The following is a description of a gene set: Human Gene Set: GSE24972_WT_VS_IRF8_KO_MARGINAL_ZONE_SPLEEN_BCELL_UP Conditional IRF8 KO mice (mice with a conditional allele of Irf8 crossed with CD19-Cre mice) showed increased numbers of both Gene expression data spleen marginal zone (MZ) and Gene expression data spleen follicular (FO) B cells compared to control mice. To evaluate gene expression patterns that distinguished FO or MZ B cells derived from conditional KO and control mice, we used Affymetrix GeneChip® Mouse gene 1.0 ST Array. from publication Feng J, Wang H, Shin DM, Masiuk M, Qi CF, Morse HC 3rd (PMID 21178004) species: Homo sapiens Genes up-regulated in spleen marginal zone B lymphocytes: wildtype versus IRF8 knockout., and this is the list of marker genes: HEMGN, SLC2A8, EXTL3, GATA6, GATA1, ADAMTS1, RAB39A (NCBI Gene Id 54734), HSPB1, SFMBT2, MDP1, ADAM8 (ADAM metallopeptidase domain 8), CARHSP1, ARHGEF12, TRPC4, MT1E, CAPN2, PCMTD2, NRG4, RBM47, ELOF1, CSRNP1, CTDSP1, NR2C2AP, SLC22A16, TMEM222 (transmembrane protein 222), CCDC59, ZNF740, CFAP119, IL1RN, IRF2BPL, ACTR10, WIPI2, KANSL1 (NCBI Gene Id 791085), PORCN, MCEE, SLMAP, MST1R, MRPL2, FMO5, AFAP1L1, UFM1, INPP4A, WDR45, STX5, GUSB, LMNA, PAPOLB, COX4I1, TMEM150B, CYP2R1, PDZD11, TMTC3, WIPI1, CEPT1, SH3PXD2B, FABP4, FASTKD1, MYD88, NAB1, COL18A1 (collagen type XVIII alpha 1 chain), KLF15, BABAM1, RCSD1, RTCB, ZC3H15, DDHD1, GDA, ARHGAP19, PIGA (NCBI Gene Id 5277), PMP2, RNF169, ABL2, MED27, MGST3, INAFM1, SMURF2, SUCLG2, GAS6, RPL22L1, RGS1, KCNK6, RNASEL, FRAT1, MTDH, TMEM87B, NAAA, SNX14, ID1, RBSN, MTSS1, DRC1 (NCBI Gene Id 92749), RAB11A, HNMT, ANKRD29, TNRC6B, WDR26, NAPEPLD, RNF144B, FHIP2A, SLC66A1, HEXA, TMBIM1, LPXN, USP25, PAN3, VCL, PRR15L, APOBEC1, JUN (NCBI Gene Id 3725), PARP12, ATRNL1, ZAR1, ATP8A1 (ATPase phospholipid transporting 8A1), CAMK2N1, CPEB2 (cytoplasmic polyadenylation element binding protein 2), CNN2, GGH, CDK11B, MT3, SLC2A10, NET1, SORBS1, TERT, DEPP1, TFRC, HTATIP2, KCTD6, ZNF471, CDH18, CARD19, SELENOP, WWP1, IFT70A, EIF1AY, ALOX5AP, MRAS, ADGRE5, VPS4B, CLCN5, GPAT3, B4GALT1, CD164, TXLNG, MAP3K6, MDFIC, RIMOC1, CHP1, MFSD1, GAB2, LAMA3, SEPTIN8, SSH2, CGNL1, HIPK1, EIF4A2, SOX30, VPS26C, LIPG, ADIPOR2, DEF8, MYCBPAP, DUSP1, GOLGA1, SIRT7, VMAC, CNDP2, HTRA1, SLC26A11, MTMR14, ZFAND3, EXT1, PLPP1, ZBED4, COPG1, DOCK10, PSMD1, ULK2, CXCR4, SRP19, IKBKG, BMPR2, KRT33A, TENT5A, MPPED1, CCDC82, STXBP3, NTS, BZW2, AAMDC, FAM120B, IFNGR1 (interferon gamma receptor 1), PELI2, TSPYL4, STPG3, RAB3GAP2, OR4E2, PAG1, XBP1, FAM110C, MXI1